Given this list of marker genes GTF2H5, RPL27, RPS28, BRCC3, SRD5A3, MTHFR, DHCR24, MRPS16, KIF26A, PCLO, FOXF1, MRPS2, RAB5IF, WNT3, WNT7A, MAF, TSR2, TRRAP, SLC25A1, ALG13, GABRA3, OGT, RUSC2, GRIP1 (glutamate receptor interacting protein 1), KAT6B, ACOX1, PRR12, COG8, PEX2, OCLN, AGRN, WNT4, SMARCA2, NDE1, KCNJ5 (potassium inwardly rectifying channel subfamily J member 5), EFTUD2, CCDC47, ASH1L, FUCA1, SMAD2, RDH11, PYCR2, PPP2R3C, SAMHD1, GPC6, KATNIP, C2CD3, POMK, ACP5, TRIP11, INPPL1, NUP88, RNASEH2B, KLHL41, ARX, PRKDC (NCBI Gene Id 5591), JMJD1C, ZFX, NIPBL, EFL1, DPH1, CHST3, PUM1, STRA6, PTH1R, LETM1, FRMD4A, PCNT (NCBI Gene Id 9346), KIF14, COL11A2, USP9X, NTNG2, PLXND1, DDX59, ZMIZ1, MEF2C, POMT1, TFAP2A, RIT1, OTUD6B, CPLANE1, RAF1, MAPK8IP3, CHRNA1, GALNT2, KCNH1, NEB, FGFR1, TBCE, RPL9, RPS17 (NCBI Gene Id 6218), ALG2, ELN, YY1, KIF7, HEATR3, CRELD1, ERCC1, ANTXR1, H3-3A, STAG1, UBA2, PEX26, AKT1, FOXE1, EXOC2, PIGB, ASXL3, ALX1, STXBP1, RPL8, TMEM67, RPS20, FHL1, EDEM3, ERI1, RPL31, PEX3, GMNN, POGZ, COL11A1, SH3PXD2B, NEK9, MADD, NGLY1, FIG4, B3GAT3, CSPP1, DVL1, EXOSC9, SCN4A, DHX30, FBXO11, RNU4ATAC, CNTNAP1, OFD1, KLHL40, MED12, CCDC22, AP3D1, ZIC3, CSNK2A1, SMAD4, TMEM70, MAPK1, SLC1A4, KCNJ2, MACF1, GLIS3, UNC80, KDM6A, RRAGC, GON7, ARID2, ALG9, GATA1, ITCH, PLOD3, NEU1, MED25, KDM4B, TRAF7, ADA2, MAB21L1, ARL3, OSGEP, FOXP2, RAD21, DONSON, ACTA1, FAM20C, SLC12A2, PHGDH, UBR7, H4C9, RSPO2, TMEM94, LRP2, SNAP25, PAX7, MUSK, NAA10 (NCBI Gene Id 8260), PCDHGC4, RREB1, ALDH18A1, EIF5A, GPKOW, VAMP1, ORC4, NFIA (nuclear factor I A), RET, POC1A, KDM5A, MGAT2, MN1, RB1 (RB transcriptional corepressor 1), INTU, CRPPA, DLX4, VPS33B, COG3, SHOC2, SOX6, COL2A1, COLEC11, EXOSC2, RPL15, SLC18A3, CAMTA1, CACNA1C, QRICH1, DNMT3B, NOTCH2, CUX1, PAM16, ATP6V1B2, ZBTB18, WBP4, MARS1, TAOK1, TMEM260, UHRF1, B3GALT6, CEP104, RPL18, SLC6A9, TBX15, ZDHHC9, DYNC2LI1, RBM10, GNS, ATP6V1E1, CD96, PIGN, UGP2, AIFM1 (NCBI Gene Id 9131), PRUNE1, DPF2, SMS, CAV1, MASP1, BMPER, SETD5, WDR73, TBX2, NARS1, HMGA2, BMP4, TGFBR1, SOD1, KATNB1, SPRED1, PIBF1 (NCBI Gene Id 10464), POMGNT1, PAFAH1B1, POMT2, TXNDC15, KAT5, FANCL, TAF1, GBA1, TCTN3, LMX1B, TWIST2, AP3B1, DDB1, FGFR2, PLCB4, POR, TPM2, RPS7, WNT5A, H4C3, IPO8, HS2ST1, AFF3, ATIC, SEC24C, PIEZO2, IRX5, PYCR1, AUTS2, CEP57, FBXL4, DHX9, FRAS1, SF3B4, CDT1, MESD, KCTD1, VAC14, GLUL, NSRP1, TEFM, LBR, HMX1, FLNA, RALGAPA1, ACAN, SEPTIN9, MECP2, PPM1D, FDFT1, RPL11, VANGL2, ITGA8, ARL13B, HERC1, PPP2R5D, LARP7, GFRA1, ZC4H2, PDZD8, RARB, TMEM218, LRRC8A, NSUN6, IFT52, ZMYM2, DOCK6, KMT2D, STAG2, DAG1, TALDO1, QARS1, NALCN, ADAT3, EBF3, INSR, MAN1B1, HIRA, NAA60, TBC1D24, BRPF1, WASHC4, TOE1, PURA (NCBI Gene Id 5813), IL6ST, GJA5, DEPDC5, FANCB, SLC25A24, ARVCF, TRPV6, PEX12, PEX5, ADAMTS2, MCTP2, RNU7-1, SMG8, USP7, MYMX, VIPAS39, ACER3, PPP1R12A (NCBI Gene Id 4659), ZBTB24, SMC5, FAT4, RPL5, LMOD3 (leiomodin 3), CBL, RAP1GDS1, MKS1, PRIM1, PTPN11, HRAS, THUMPD1, MID1, FREM1, MRPL12, FBLN5, NSD1, CDK10, STAC3, AHI1, ACTB, CHRND, ZMPSTE24, RPL35A, HYLS1, HOXB1, NAA20, PLCH1, COG1, DHPS, SATB2, TBCK, GJA1, CDKN1C, CBY1, CCBE1, B4GAT1, ERCC5, HSPG2, RAC1, ADGRG6, MRPS28, PRPS1, MSL3, ARID1B, CTU2 (NCBI Gene Id 348180), PUS7, FREM2, TTI1 (TELO2 interacting protein 1), ATP6V1A, TAF4, MYOD1, CCNQ, MYSM1, ANKH, RAB3GAP1, POMGNT2, CDC6, TOGARAM1, KIF15, DST, UFC1, FLNB, LMNA, GNAI3, GPC4, GPT2, PEX1, PRKG2, TMEM237, PTF1A, TAPT1, SKI, TPM3, ATP6AP2, ESCO2, LSM11, WNK3, CHST14, FZD2, MRPS14, SOX4, MED13L, MMACHC, ASXL2, CNOT3, ZNF699, RPS19, WDR35, VPS35L, RYR1, DDX6 (NCBI Gene Id 1656), POLE, PACS1, NUP188, EP300, SON, SLC26A2, RPS26, SMC3, FBN1, DDX3X, WNT9B, LRPPRC, MRAS, CDH11, CHUK, METTL5, HELLS, SPECC1L, SPART, FGF20, IFT122, INTS11, MEIS2, MEGF8, NRAS, UFD1, SCYL2, VARS1, SETD1A, ZNF292, SOX11, TCF20 (transcription factor 20), MBD5 (NCBI Gene Id 55777), EYA1, DRG1, TMEM147, IFT74, RPL10, KIAA0753, ADSL, CHD5, RPS29, CEP120 (centrosomal protein 120), TREX1, ALG6, CACNA2D1, LMBRD1, PLAA, ADNP, STAMBP, IFT140, DPYSL5, CCNK, MAPRE2, COLEC10 (collectin subfamily member 10), KMT2A, TWIST1, COG7, PSMD12, UBE3B, ANTXR2, ANO1, SPRED2, EFEMP2, PHOX2B, CAMK2G, CLCN3, KAT8, B9D2, SIAH1, GLE1, BCOR, MYCN, PRRX1, FKRP, DVL3, PLAG1, PTCH1, B4GALT1, B4GALT7, ORC1, GNB2, SMG9, SUPT16H, WARS2, CENPJ, EIF4A3, TRIP12, ZNF462, WNT7B, CDC45, KRAS, BICRA, RNASEH2C, CNOT1, ATRX, MAP3K7, TRIP13, SLC39A8, RIPK4, AP1G1, HDAC6, SKIC3, IGBP1, ERCC4, ALX3, MARS2, PLAAT3, MED27, CC2D2A (NCBI Gene Id 57545), SLC37A4, PDE6D, PPP1R21, TMEM216, KYNU, PAX1, IFT56, SMARCD2, C12orf57, SOX9, CDC42BPB, SPOP, RPL35, MYO9A, WDR37, FGFR3, BRF1, TGDS, BAP1 (NCBI Gene Id 8314), NOTCH3, MCM5, SPINT2, ADAMTS15, CDC42, KIFBP, RPGRIP1L, FRA10AC1, LARGE1, B9D1, CDCA7, ARMC9, CCN2, NFIX, PAICS, CHD7, LIFR, ZSWIM6, PITX1, DYRK1A, MRPS22, BLTP1, TMEM107 (transmembrane protein 107), ADAMTS3 (ADAM metallopeptidase with thrombospondin type 1 motif 3), FOXL2, PBX1, OTUD5 (OTU deubiquitinase 5), RPS15A, EXOC7, PKHD1, TMEM165, INPP5E, IGF1R, CREBBP, SCO2, GAD1, MAGEL2 (MAGE family member L2), PLVAP, ALG8, BRAF, CWC27 (NCBI Gene Id 10283), COL4A1, CTSD, PSAT1, PIK3R1 (phosphoinositide-3-kinase regulatory subunit 1), GK, PCGF2, CRLF1, IREB2, PHACTR1, DPH2, JARID2, U2AF2, GJA8, RPS24, TMCO1, CDK13 (cyclin dependent kinase 13), TUBB, PTEN, GP1BB, TTC5, CNOT2, CEP152, CHD4, SNRPB, ROR2, RAB23, CHRNG, CTCF (NCBI Gene Id 10664), COL13A1, MYH3, CPT2, POLR3A, WBP11, RNU4-2, TFAP2B, POLR1A, COG5 (component of oligomeric golgi complex 5), RAPSN, MINPP1, NECTIN1, SUFU, GNPTAB, EED, BMP2, TBX1, ASXL1, SMOC1, MVK, CENPF, HSD17B4, GLB1, RERE, RPS23, RAB3GAP2, FGF10, RAP1B, ALX4, EPG5, EDNRA, CILK1, TUBB3, BRD4, ATN1, DNM1, SLC5A7, CHAMP1, SOX5, DHODH, YWHAE, SIM1, NF1 (neurofibromin 1), B3GALNT2, AMER1, TENM3, IFT81, IGF2, RPL26, PORCN, DZIP1L, GREB1L, HUWE1, CHAT, PIGT, CHMP1A, PPP1CB, WASHC5, SPEN, NXN, ATP2B1, RNASEH2A, CHSY1, KAT6A, SCNM1 (NCBI Gene Id 79005), FKTN, GATA4, BUB1B, PRDX1, DHCR7, RXYLT1 (ribitol xylosyltransferase 1), CEP41, KCNK4, SETBP1, AHDC1, RELN, SOS1, ATR, CEP55, PEX10, RALA, DIS3L2, RPS10, SYT2, MAP2K1, IFIH1, ORC6 (origin recognition complex subunit 6), JAG1, SRRM2, BCL11A, TCTN2, CHD3, TSPEAR, RAB34, CDH2, GTPBP2, RSPRY1, PIGU, RECQL4, MYO18B, NAA80, HNRNPH1, GNE, COMT, EEF1A2, XYLT2, EBP, SLC4A10, UPF3B, SRCAP, MBTPS2, RPS27, H4C5 (NCBI Gene Id 8367), KIAA0586, ATP6V0A2, B3GLCT, HS6ST2, FANCD2, LZTR1, BMPR1A, DDR2, ZNF148, DCPS, ADAR, INTS1, TASP1, ALDH1A2 (NCBI Gene Id 8854), TCTN1, here is a description of the gene set: Human Gene Set: HP_LOW_SET_EARS species: Homo sapiens Upper insertion of the ear to the scalp below an imaginary horizontal line drawn between the inner canthi of the eye and extending posteriorly to the ear. Low-set ears